Given this list of marker genes Il1b, Kcnq5, Rps3a1, mt-Nd4l (NCBI Gene Id 17720), S100a4 (NCBI Gene Id 20198), Rpl8, Gda, Tyrobp, H2-Q10, Timp1, Cxcl3, Ifit3, Mt1, Hk2, Mcemp1, B2m, Ier3 (NCBI Gene Id 15937), H2bc4, Rpl17, Rack1 (receptor for activated C kinase 1), Gadd45a, Txnip, Rpl30, Fgl2, Ifi27l2a, Nqo1, Ccl6, S100a9, H3f3b, Rps20, Ubd, Ucp2, Rpl5, Gapdh, Trf, Rpl18a, Rplp0, Cxcr4, Eef1a1, Ccl3, Oasl1, Serpinb1a, Tspo, Ctsh, Slpi, Lrg1, Rplp1 (ribosomal protein lateral stalk subunit P1), Fth1, Srgn, Xdh, Rpl12, Dmd, Myog, Pglyrp1, Mt2, Fcer1g, Il6, Mgst1, Eda2r, Ltbp1, Ppp1r27 (NCBI Gene Id 68701), Lyz2, Lgals3, Gpnmb, Rgcc, Dclk1, Ifitm1, Napsa, Rgs2, Upp1, Ppt1, Clec7a, Odc1, Rps12, Ankrd1 (ankyrin repeat domain 1), Eef2, Prdx5, Rpl7, Gzmk, S100a8, Anxa1, G0s2, Errfi1, Cxcl2, Runx1, Oas1a, Mybph, Car3, Procr, Sdc4, Tmem176a, Plac8 (NCBI Gene Id 28008), Rps24, Chi3l1, Rps6, Nfkbia, AA467197, Hp, Sod2, Tmsb4x, Serpine1, C1s1, H2-Eb1, Capg, Enc1, here is a description of the gene set: Genes up-regulated across multiple cell types from nine tissues during rat aging. Mouse Gene Set: MA_RAT_AGING_UP species: Rattus norvegicus Aging causes a functional decline in tissues throughout the body that may be delayed by caloric restriction (CR). However, the cellular profiles and signatures of aging, as well as those ameliorated by CR, remain unclear. Here, we built comprehensive single-cell and single-nucleus transcriptomic atlases across various rat tissues undergoing aging and CR. CR attenuated aging-related changes in cell type composition, gene expression, and core transcriptional regulatory networks. Immune cells were increased during aging, and CR favorably reversed the aging-disturbed immune ecosystem. Computational prediction revealed that the abnormal cell-cell communication patterns observed during aging, including the excessive proinflammatory ligand-receptor interplay, were reversed by CR. Our work provides multi-tissue single-cell transcriptional landscapes associated with aging and CR in a mammal, enhances our understanding of the robustness of CR as a geroprotective intervention, and uncovers how metabolic intervention can act upon the immune system to modify the process of aging. from publication Ma S, Sun S, Geng L, Song M, Wang W, Ye Y, Ji Q, Zou Z, Wang S, He X, Li W, Esteban CR, Long X, Guo G, Chan P, Zhou Q, Belmonte JCI, Zhang W, Qu J, Liu GH (PMID 32109414)